The following is a description of a gene set: FCERI mediated Ca+2 mobilization Human Gene Set: REACTOME_FCERI_MEDIATED_CA_2_MOBILIZATION species: Homo sapiens, and this is the list of marker genes: IGKV1-17, IGKV2D-30, IGLV3-27, IGKV3-20, IGLV3-19, IGLV6-57, IGHV3-13, IGHV4-59, FCER1A, IGLV7-43, IGLV3-25, CALM1, VAV1 (NCBI Gene Id 7409), IGHV2-5, IGKV1-5, VAV3, NFATC1, IGHV3-48 (immunoglobulin heavy variable 3-48), ITPR3, IGHV3-53, IGLV1-51, IGKV2-28, IGLV1-40, ITPR2, IGKV1D-12, IGKV1D-33, IGKV1D-39, IGKV5-2, PPP3CB, IGLV2-11, IGKV2D-40, IGLV1-47, AHCYL1, LAT, FCER1G, NFATC2, ITK, VAV2 (vav guanine nucleotide exchange factor 2), IGKV2D-28, IGHV4-39, IGHV1-69, IGLC2, IGHV3-11, ITPR1, IGKV1-33, IGLV3-1, TEC, IGLV2-14, IGKV2-30, IGLV1-44, IGHE, IGHV3-33, SHC1, PPP3CA, PLCG1, IGHV2-70, PPP3R1, IGKV3-11, GRAP2, IGHV3-30, SOS1, IGKV3D-20, LYN, GRB2, IGKV1D-16, IGLV2-8, IGLV3-21, IGKV1-39, IGLC3, IGHV3-7, IGKV3-15, SYK, NFATC3, MS4A2, LCP2, IGLV2-23, IGKV1-12, IGHV4-34, IGHV3-23, BTK, IGHV1-2, IGKV1-16, TXK, IGHV1-46, IGKV4-1, PLCG2